The following is a description of a gene set: Human Gene Set: MIR4302 Genes predicted to be targets of miRBase v22 microRNA hsa-miR-4302 in miRDB v6.0 with MirTarget v4 prediction scores > 80 (high confidence targets). species: Homo sapiens from publication Chen Y, Wang X (PMID 31504780), and this is the list of marker genes: PDCD10, TBCC, NR1D2, DAZ2, GALNT4, TWF1, DDX46, OSBPL8, PDE3A, STXBP1, DAZ3, PAXBP1, RPS6KA3 (NCBI Gene Id 6197), ITPR2, KCNK3, KCNK10, ZNF587B, KMT2E, PPDPFL, EYA4, SMG7, RNF38, ZNF75A, CECR2, FZD6, TPMT, LIFR, STAM, FSD2, CDH12, KLHL29, PSMA7, ZNF773, CREM, KIF13A, ZNF426, MAP3K5, PCM1, KCNIP4, CHCHD4, CHD1, ACYP2, EBF3, HIPK3 (homeodomain interacting protein kinase 3), FBXW8, MAPK4, MBNL1, ENTREP3, SLC2A8, MAP4K3, ZNF763, COCH, SLC5A9, CYP46A1, ERLIN1, SIX4, PRDM11, KMT5B, PLXDC2, ADAMTS6 (ADAM metallopeptidase with thrombospondin type 1 motif 6), INPP5A (inositol polyphosphate-5-phosphatase A), ZNF559, ZNF121, CIMAP3, PTPRG, ITGB1BP1 (NCBI Gene Id 9270), SH3PXD2A, FGFR2, SREK1, ARHGEF11, ZNF544, POLR2J3, HEYL, POC1B-GALNT4, QTRT2 (NCBI Gene Id 79691), ABI3BP, FABP2, ZNF844, ELAVL4, TSEN34, PNKD, DENND6A, TENT4B, MSI2, KLF4, DAZ4, SP3, ZFP90, LZTS2, RAI1, MTCL3, CACUL1, AKR7A2, RUNX3, KAT2B, KIF5A, PLXNA2, ABHD17B, PGAM1, PHF6, NKAIN2, DAZ1, UBXN4, ZNF329, CD46, MAP3K20 (NCBI Gene Id 51784), BUB1, LRRC10, INHBA, CXXC4, ZNF559-ZNF177 (NCBI Gene Id 100529215), STAC, GOSR2, NREP, ZNF195, TBX15, ROCK1, POLR2J2, NCR2, GAB3, CDK6, SHOC2, FGD6, ZNF439, ZNF189, KATNBL1 (katanin regulatory subunit B1 like 1), PDS5A, ZBTB8A (NCBI Gene Id 730411), TARS3 (NCBI Gene Id 123283), THBS1, ITGA3, YOD1, EPAS1